Given this list of marker genes Psmb3, Psmb1, Exosc9, Exosc3, Exosc5, Prkcd, Anp32a, Akt1, Psmd14, Uba52rt, Psmb7, Khsrp (KH-type splicing regulatory protein), Psmb6, Psmd7, Zfp36, Psmd12, Eif4g1, Zfp36l1, Exosc8, Psmd6, Psmc2, Tnpo1, Mapkapk2, Ubc (ubiquitin C), Psmc3, Hspa8, Dcp2, Psmc6, Psmb5 (NCBI Gene Id 19173), Hspb1 (heat shock protein 1), Exosc6, Exosc7, Pabpc1, Hspa1b (NCBI Gene Id 15511), Psmd13, Psmd1, Ywhaz, Exosc4, Hspa1a, Nup214, Exosc1, Ywhab, Uba52, Psmd3, Psma3, Xrn1, Xpo1, Tnfsf13, Psma6, Rps27a, Psmd2, Hnrnpd, Psmc1, Psmb2, Psma2, Psma7, Set, Dcp1a, Psmb4, Psma1, Psmd8, Parn, Exosc2, Ubb, Psmd11, Dis3, Elavl1, Psma5, Psma4, Psmc5, Psmc4, Adrm1, here is a description of the gene set: Regulation of mRNA stability by proteins that bind AU-rich elements Mouse Gene Set: REACTOME_REGULATION_OF_MRNA_STABILITY_BY_PROTEINS_THAT_BIND_AU_RICH_ELEMENTS species: Mus musculus